The following is a description of a gene set: species: Homo sapiens Human Gene Set: GOBP_REGULATION_OF_MITOCHONDRIAL_DEPOLARIZATION Any process that modulates the frequency, rate or extent of the change in the membrane potential of the mitochondria from negative to positive., and this is the list of marker genes: GCLM, GOT1, ABCD1, TSPO, ADCY10, BOK, PARP1, BCL2, KDR, ALB, GCLC, SRC, IFI6, PPP2R3C, LRRK2, MYOC, HSH2D, MLLT11, DCN, P2RX7, FZD9, RACK1